The following is a description of a gene set: Mouse Gene Set: REACTOME_CONJUGATION_OF_SALICYLATE_WITH_GLYCINE Conjugation of salicylate with glycine species: Mus musculus, and this is the list of marker genes: Acsm2, Glyatl3, Acsm4, Acsm5, Glyat